Given this list of marker genes Nlgn1, Prkce, Adra1a (adrenergic receptor, alpha 1a), Car7, Nalcn, Oxtr, Hap1, Zdhhc12, Tacr1, Kif5b, Nps, Tac1, Nlgn2, Grik1, Erbb4, Cckbr, Nrxn1, Zdhhc3, Adora2a, Car2, here is a description of the gene set: Any process that activates, maintains or increases the frequency, rate or extent of GABAergic synaptic transmission, the process of communication from a neuron to another neuron across a synapse using the neurotransmitter gamma-aminobutyric acid (GABA). studied in species Mus musculus Mouse Gene Set: GOBP_POSITIVE_REGULATION_OF_SYNAPTIC_TRANSMISSION_GABAERGIC